The following is a description of a gene set: studied in species Homo sapiens The progression of the brainstem from its formation to the mature structure. The brainstem is the part of the brain that connects the brain with the spinal cord. Human Gene Set: GOBP_BRAINSTEM_DEVELOPMENT, and this is the list of marker genes: PHOX2B, ATF2, GART, SMAD4, NLGN4X, SCN5A, CNTFR (ciliary neurotrophic factor receptor), ATIC